Given this list of marker genes FCGR3A, IKBKG (inhibitor of nuclear factor kappa B kinase regulatory subunit gamma), WAS, WIPF1, LCP2, AP3B1, UNC13D, SH2D1A, STXBP2, PRKCD, PIK3CD, IL2RG, STX11, PRF1, XIAP, NLRC4, here is a description of the gene set: Abnormal response of natural killer (NK) cells to stimuli. Abnormal natural killer cell physiology Human Gene Set: HP_ABNORMAL_NATURAL_KILLER_CELL_PHYSIOLOGY studied in species Homo sapiens